The following is a description of a gene set: studied in species Mus musculus Mouse Gene Set: GOBP_REGULATION_OF_PROTEIN_DEACETYLATION Any process that modulates the rate, frequency, or extent of protein deacetylation, the removal of an acetyl group from a protein amino acid. An acetyl group is CH3CO-, derived from acetic acid., and this is the list of marker genes: Hdac2, Brms1, Ccar2, Fry, Bex4 (brain expressed X-linked 4), Zzz3, Kat2a, Fnta, Ndn, Dr1, Sirt1 (sirtuin 1), Kat14, Tada2a, Mapt, Ep300, Tppp, Bex6, Nek3, Prkaa1, Ifng, Tada3, Yeats2, Ncor2, Prkaa2, Wdr5, Nnmt, Sgf29, Mbip